Given this list of marker genes Sgo1, Cdk11b, Meikin, Naa10, Sgo2a, Bub1, Ctnnb1, Ppp2r1a, Bub1b, Ppp2r1b, Axin2, Naa50, here is a description of the gene set: The cell cycle process in which the sister chromatids of a replicated chromosome are joined along the length of the centromeric region of the chromosome. studied in species Mus musculus Mouse Gene Set: GOBP_CENTROMERIC_SISTER_CHROMATID_COHESION